Given this list of marker genes SLC7A7, ADA2, PAX2, ALG9, DNAJB11, G6PC1, CLCNKB, HGD, AGXT, SLC2A9 (NCBI Gene Id 56606), IFT140, SLC34A1, CLCNKA, PKD2, PBX1, SLC22A12, SLC37A4, UMOD, BICC1, PUS3, CASR, SEC61A1 (NCBI Gene Id 83289), ITGA3, CYB561, GANAB (glucosidase II alpha subunit), MUC1, PKD1, BSND, ALG5, here is a description of the gene set: Decreased glomerular filtration rate An abnormal reduction in the volume of fluid filtered out of plasma through glomerular capillary walls into Bowman's capsules per unit of time. studied in species Homo sapiens Human Gene Set: HP_DECREASED_GLOMERULAR_FILTRATION_RATE